The following is a description of a gene set: Human Gene Set: GOBP_REGULATION_OF_NUCLEOTIDE_BINDING_OLIGOMERIZATION_DOMAIN_CONTAINING_2_SIGNALING_PATHWAY studied in species Homo sapiens Any process that modulates the frequency, rate, or extent of the nucleotide-binding oligomerization domain containing 2 (NOD2) pathway., and this is the list of marker genes: TNFAIP3, TLR4, SLC15A3 (solute carrier family 15 member 3), ERBIN, ZNRF4, PTPN22, HSPA1A, HSPA1B, NAGK, SLC15A4